Given this list of marker genes SDC3 (syndecan 3), SDC1, AGRN, GPC2, SDC2, GPC5, EXT1, GPC1, HSPG2 (NCBI Gene Id 7796), EXT2, GPC4, GPC3, GPC6, SDC4 (NCBI Gene Id 6385), here is a description of the gene set: Reactome Pathway: Defective EXT1 causes exostoses 1, TRPS2 and CHDS Heparan sulfate (HS) is involved in regulating various body functions functions during development, homeostasis and pathology including blood clotting, angiogenesis and metastasis of cancer cells. Exostosin 1 and 2 (EXT1 and 2) glycosyltransferases are required to form HS. They are able to transfer N-acetylglucosamine (GlcNAc) and glucuronate (GlcA) to HS during its synthesis. The functional form of these enzymes appears to be a complex of the two located on the Golgi membrane. Defects in either EXT1 or EXT2 can cause hereditary multiple exostoses 1 and 2 respectively (MIM:133700 and MIM:133701), autosomal dominant disorders characterized by multiple projections of bone capped by cartilage resulting in deformed legs, forearms and hands. Trichorhinophalangeal syndrome, type II (TRPS2 aka Langer-Giedion syndrome, LGS) is a disorder that combines the clinical features of trichorhinophalangeal syndrome type I (TRPS1, MIM:190350) and multiple exostoses type I, caused by mutations in the TRPS1 and EXT1 genes, respectively. Defects in EXT1 may also be responsible for chondrosarcoma (CHDS; MIM:215300) (Schajowicz & Bessone 1967, Hecht et al. 1995). studied in species Homo sapiens part of: Diseases associated with glycosaminoglycan metabolism